Given this list of marker genes ROCK1, ROCK2, NHERF1, RHOA, EZR, here is a description of the gene set: Human Gene Set: KEGG_MEDICUS_PATHOGEN_ESCHERICHIA_MAP_TO_LPA_GNA12_13_RHOA_SIGNALING_PATHWAY Escherichia Map to LPA-GNA12/13-RhoA signaling pathway. Pathway ID: N01095. Pathway type: Pathogen. Pathway class: nt06135 Cytoskeletal regulation (viruses and bacteria). Pathway Definition from KEGG: Map -> NHERF1 -> EZR -> RHOA -> ROCK1/2 studied in species Homo sapiens